The following is a description of a gene set: Genes in the cancer module 133. studied in species Homo sapiens Human Gene Set: MODULE_133, and this is the list of marker genes: QARS1, EPRS1, SARS1, NARS1, TARS1, VARS1, FARSA, AARS1, HARS1, KARS1, CARS1, IARS1, DARS1, YARS1, GARS1